Given this list of marker genes ACADL, TMLHE, ACADM, CPT1B, CHDH, CRAT, CPT2, ALDH9A1, DMGDH, ALDH7A1, BHMT2, BBOX1, BHMT, POR, SLC22A4, CROT, SHMT1, CPT1C, CPT1A, here is a description of the gene set: species: Homo sapiens Human Gene Set: GOBP_AMINO_ACID_BETAINE_METABOLIC_PROCESS The chemical reactions and pathways involving any betaine, the N-trimethyl derivative of an amino acid.